Given this list of marker genes Lrrk2, Hnrnpk, Mecp2, Rtn4, Il1b, Shox2, Bcl11a, Cpe, Map3k13, here is a description of the gene set: studied in species Mus musculus Any process that modulates the frequency, rate or extent of branching morphogenesis of a nerve. Mouse Gene Set: GOBP_REGULATION_OF_BRANCHING_MORPHOGENESIS_OF_A_NERVE